Given this list of marker genes TAFAZZIN, SLC22A5, GJA5, CSRP3, MCM10, ACTN2, ALPK3, IDUA, here is a description of the gene set: species: Homo sapiens Diffuse thickening of the ventricular endocardium and by associated myocardial dysfunction Human Gene Set: HP_ENDOCARDIAL_FIBROELASTOSIS Endocardial fibroelastosis